Given this list of marker genes Htr2a, Pcp4, Syt11, Oprk1, Syt7 (NCBI Gene Id 78663), Drd3, Pink1 (PTEN induced putative kinase 1), Prkcb, Entpd1, Gnat1, Tgm2, Cxcl12, Gabbr1, Slc18a1, Chrna6, Drd2, Rab3a, Comt, Cnr1, Dtnbp1, Xlr4b (NCBI Gene Id 27083), Kcna2, Htr6, Slc18a2 (NCBI Gene Id 68754), Npy2r, Myo5a, Htr1b, Chrna4, Xlr4a, Sncg, Chrnb2, Abat (NCBI Gene Id 57428), Syt4, Snca (NCBI Gene Id 20617), Rtn4, Grm2, Kpna4, Syt1, here is a description of the gene set: Mouse Gene Set: GOBP_DOPAMINE_SECRETION The regulated release of dopamine by a cell. Dopamine is a catecholamine and a precursor of adrenaline and noradrenaline. It acts as a neurotransmitter in the central nervous system but it is also produced peripherally and acts as a hormone. species: Mus musculus